Given this list of marker genes UPP1, MAP3K5, ITPR1, ACTR2, ATP5IF1, ARPC1A, PSMD1, COL18A1, LHCGR, ACP2, FKBP5, PPP2R5B, PTPN21 (NCBI Gene Id 11099), PSMC3, RHOB, P4HA2, PGK1 (phosphoglycerate kinase 1), GRK5, RAB4A, DUSP1, HSD3B1, CD55, MAP2K1, BAD, CDK16, GDI2, TMBIM6 (transmembrane BAX inhibitor motif containing 6), HSD11B1, RAB2A, GK, PRKAR1A, PDXK, SGK1, GNB1, GDE1, DHCR7, GNLY, ADGRG1, ACP3, MAP1LC3B2, CREBL2, CDC42EP4, GPRC5B, FDXR (NCBI Gene Id 2232), STK25, RAB27A, NOL3, PTP4A1, GNAS, PTPRN, CASP9, STIP1 (stress induced phosphoprotein 1), PPFIA4, PLIN3, ATP2B1, BAG1, PTPRF, ALPL, HSD3B2, DUSP3, ARHGAP35, PPP2R1A (protein phosphatase 2 scaffold subunit Aalpha), TK1, ARHGEF5, TNFAIP3, RAB1A, BNIP3L, PLPP1, DDX41, PGRMC1, COL15A1, JMJD6, TFPI2, NLK, CYP11A1, CYP19A1, RAB5A, DUSP9, PHKA2, STAR, POP5, RAB14, MAP3K7, MSMO1, ACTB, PRKX, here is a description of the gene set: Gonadotrophins exert a major effect on ovarian development and on the control of fertilization. By stimulating cells with forskolin (FK), it is possible to study which genes are activated by gonadotrophins via the cAMP cascade, and which by alternative pathways. Using RNA isolated from stimulated cells, we found that 59% of the total genes modulated by LH were also modulated by FK, while 69% of the genes modulated exclusively by FSH were also modulated by FK. Gene transcripts involved in steroidogenesis/progesterone production were highly elevated, while 17beta-hydroxysteroid dehydrogenase was down-regulated. This suggests that a decrease in the conversion of androstenedione to testosterone and estrone to estradiol occurs during luteinization. Down-regulation of genes coding for actin cytoskeleton proteins and cytokeratin 18 was observed in response to gonadotrophin and cAMP stimulation. Several of the genes coding for the microtubule network were also modulated, implying that rearrangement of the cytoskeletal proteins permits better coupling between organelles involved in steroidogenesis. A dramatic change in gene transcripts coding for signalling enzymes was observed following LH stimulation. This includes the down-regulation of adenylyl cyclase 7 and 9, elevation of cAMP-dependent phosphodiesterase, and the up-regulation of a negative regulator of G-protein signalling (RGS16) that may negate gonadotrophin signalling via guanine nucleotide binding proteins. Thus luteinized cells, despite increased gene transcripts to LH/chorionic gonadotrophin (CG) receptors, respond inefficiently to gonadotrophin stimulation, due to attenuation of signal transduction in the cAMP cascade at multiple steps. Novel genes involved in the regulation of apoptosis were found for the first time to be up-regulated by gonadotrophin stimulation, including: BAX inhibitor-1, granulysin and apoptosis repressor with caspase recruitment domain (ARC). These proteins may be involved in a unique alternative pathway of ovarian cell death. Such a pathway could temporarily preserve the mitochondria and progesterone production during the initial stages of granulosa cell apoptosis. Human Gene Set: SASSON_RESPONSE_TO_GONADOTROPHINS_UP from publication Sasson R, Rimon E, Dantes A, Cohen T, Shinder V, Land-Bracha A, Amsterdam A (PMID 15026540) Genes up-regulated in primary granulosa cells after stimulation with LH or FSH gonadotrophic hormones for 24 h. species: Homo sapiens